The following is a description of a gene set: Human Gene Set: GSE11057_PBMC_VS_MEM_CD4_TCELL_UP from publication Abbas AR, Wolslegel K, Seshasayee D, Modrusan Z, Clark HF (PMID 19568420) Microarray deconvolution is a technique for quantifying the relative abundance of constituent cells in a mixture based on that mixture's microarray signature and the signatures of the purified constituents. It has been applied to yeast and other systems but not to blood samples. Here we test the ability of this technique to determine the fractions of subsets of memory T cells in peripheral blood mononuclear cell (PBMC) samples. studied in species Homo sapiens Genes up-regulated in comparison of peripheral mononuclear blood cells (PBMC) versus memory T cells., and this is the list of marker genes: PTGS1, IGSF6, EPB41L3, NUDT16 (NCBI Gene Id 131870), AOAH, LILRB2, PAX5, STEAP4, ATP8B4, HDC, FES, LYST, IFI30, DGAT2, TFEC, IGKV1D-13, P2RY12, TMEM40, TMEM121B, RASSF4, CTSS, IGFBP7, SPRED1, ASRGL1, SIRPB2, RAB32, STAB1, DOCK5, CACNA2D3, FCGRT, MEF2C, PLXNB2, RNF144B, LTBR, SLC15A3, CYP1B1, AATBC, PRKCD, MTMR11, SMPDL3A, TREM1, LGALSL, PF4, C5AR1, ARPIN (NCBI Gene Id 348110), BST1, CD79A, ZEB2, TCF4, DYSF, SCPEP1, GNG11, IGHD, CXCL5, FPR2, CES1, LTA4H, SCARB1, LPCAT2, RBP7, TNFAIP2, ASAH1, SLC46A2, CD300LB, ZFHX3, MAFB, ASGR1, PDGFC, FCGR2A, CYP27A1, TLR4, ADAM9, LRRK2, SORT1, ALDH1A1, SLC31A2, ZNF385A, SLC22A15, KCNE3, TET2, TM6SF1, CYBRD1, RHOBTB1, LINC00968, CD86, SLC37A2 (NCBI Gene Id 219855), FCGR2C, LILRA1 (leukocyte immunoglobulin like receptor A1), TBC1D8 (NCBI Gene Id 11138), CCR1, ASAP2, ADGRE2, CRISPLD2, TTYH3, VSTM1, BMP2K, CD180, IL13RA1, HK3, CD8B, PLA2G7, CEBPA, ITPRIPL2, PIP5K1B, MCEMP1, CARD9, OAZ2, HLA-DOA, TCL1A, LILRB1, SYNGR1, QPCT, LILRA6, ARL11, PTX3, SGMS2, RUBCNL, FMNL2, KYNU, CYRIA, CSF2RA, TNFRSF17, CD1C, RNASE6, ACRBP, ITGA2B, CLEC4E, GRK3, NRGN, B3GNT5, PYGL, KIR2DL3, CSF3R, ATP6V0A1, JUP, DUSP6, NFAM1, WDFY4, RTN1, PLA2G4A, CPPED1 (NCBI Gene Id 55313), TMEM170B, SPARC, LILRB3, SPI1, CD300LF, SRGN, NEXN, F13A1, HMOX1, IL18, RNASE2, TMEM176B, FCER1A, SOX4, SWAP70, PCDH9 (NCBI Gene Id 57123), CLEC4A, CD19, P2RY13, SLC7A7, MXD1 (MAX dimerization protein 1), SLC2A6, MYOF, MYL9, TUBB1, HVCN1, ANPEP, CA2 (carbonic anhydrase 2), LGALS2, TNFRSF8 (NCBI Gene Id 943), MARCHF1, CD163, SIRPB1, CMKLR1, MS4A3, NFE2, OSCAR, RXRA, CCDC88A, ASGR2, IGKC, SHTN1, NAGK, FGD4, PTAFR, FBN2, RAB31, SERPINB2, FCRL1, MARCKS, PRKAR2B, OLIG1, MYCL, CD160, IL1RN, PADI4